Given this list of marker genes JAK2, IL12RB1, TYK2, P4HB, STAT3 (NCBI Gene Id 6774), IL12B, IL23A, IL23R, STAT4, here is a description of the gene set: Interleukin-23 (IL23) is a heterodimer of Interleukin-12 subunit beta (IL12B, IL-12p40), which is shared with IL12, and Interleukin-23 subunit alpha IL23A (IL-23p19) subunit. The functional receptor for IL23 consists of Interleukin-12 receptor subunit beta-1 (IL12RB1), which is shared with the IL12 receptor, and Interleukin-23 receptor (IL23R). IL23R is mainly expresed on activated memory T cells, Natural Killer cells, monocytes/macrophage and at low levels on dendritic cells (DCs). IL23 is mainly secreted by activated macrophages and DCs in peripheral tissues such as skin, intestinal mucosa and lung. IL23 is proinlflammatory and implicated in several autoimmune inflammatory disorders such as colitis, gastritis, psoriasis and arthritis. It is similar to IL-12 both in structure and its ability to memory T cells to increase interferon-γ (IFN-γ) production and proliferation, the ability of IL-23 to induce IL-17. IL23 activates the Janus kinases JAK2 and TYK2, resulting in phosphorylation of the receptor complex, which forms the docking sites for Signal transducer and activator of transcription 3 (STAT3) and STAT4 to bind and become phosphorylated. part of: Interleukin-12 family signaling species: Homo sapiens Reactome Pathway: Interleukin-23 signaling